Given this list of marker genes Zfp410, Mbd2, Zfp869, Mindy2, Cdk5r2, Rab8a, Nptx2, here is a description of the gene set: Genes predicted to be targets of miRBase v22 microRNA mmu_miR_12184_3p in miRDB v6.0 with MirTarget v4 prediction scores > 80 (high confidence targets). Mouse Gene Set: MIR_12184_3P from publication Chen Y, Wang X (PMID 31504780) studied in species Mus musculus